Given this list of marker genes Nrp1, Abl1, Abl2, Espnl, Arhgef10l, Mtor, Arhgef10, Fscn1, Fam171a1, Nox4, Pak1, Limch1, Wnt11, Srf, Pdlim4, Pawr, Pik3r1, Myoc, Ccdc88a, Kank4, Ptger4, Lima1, Pls3, Tmeff2, Dpysl3, Cfl1, Kctd13, Rflna, Vil1, Luzp1, Kank2 (KN motif and ankyrin repeat domains 2), Aif1l, Aif1 (NCBI Gene Id 56250), Ptk2b, Sh3pxd2b, Arhgef18, Zyx, Actg1, Inpp5k, Stmn1, Nf2, Flna, Espn, Myh9, Baiap2, Myh10, Was, F11r, Phldb2, Fmn2, Pfn1, Met (NCBI Gene Id 194383), Shroom2, Tsc1, Asap3, Sorbs1, Carmil1, Arap1, Itgb1, Dnm2, Synpo, Kank3, Rhpn2, Bloc1s6, Rhoc, Frmd7, Serpinf2, Itgb1bp1, Swap70, Map3k1, Ush1c, Sdc4, Ezr, Shank1, Lpar1, Spag6l, Fermt2, Wnt4, Tmsb15l, Pdxp, Arrb1, Bag4, Shank3, Fam107a, Add1 (adducin 1), Tjp1, Fhdc1, Arhgap6, Tac1, Bbs4, Ppp1r9a, Smad3, Spire1, Tgfb3, S1pr1, Tpm1, Ccn2, Spire2, Evl, Baiap2l2, S100a10, Limk1, Coro2b, Arhgef5, Sorbs3, Clasp2, Tgfbr1, Dbnl, Rapgef3, Src, Tnfaip1, Cd47, Tacr1, Coro1b, Pfn2, Baiap2l1, Fscn2, Arhgap28, Pfn3, Dmtn, Cul3, Kiss1r, Tesk1, Phactr1, Wasf2, Alms1, Epha1, Gas7, Myo1b, Fhod1, Ttc8, Pfn5, Limd2, Actn1, Cald1, Pik3r2, Synpo2, Synpo2l, Myl9, Actn4, Hsp90b1, Zeb2, Marcks, Rhoa, Pak2, Cx3cl1, Tacstd2 (tumor-associated calcium signal transducer 2), Cdc42, Mtss1, Pxn, Arhgef15, Pls1, Dlc1, Fscn3, Pdlim1, Shroom1 (shroom family member 1), Ppm1f, Prkn, Rflnb (NCBI Gene Id 76566), Itgb5, 4930544G11Rik, Tmsb15b2, Mkks, Eln, Rhod, Gpr65, Braf, Diaph3, Apoa1, Cgnl1, Rgcc, Rac1, Plek, Ppm1e, Dbn1, Add2, Rhpn1, Lcp1, Clasp1, Prkcq, Rdx, Id1, Shtn1, Eps8, Rock2, Ppfia1, here is a description of the gene set: A process that results in the assembly, arrangement of constituent parts, or disassembly of an actin filament bundle. Mouse Gene Set: GOBP_ACTIN_FILAMENT_BUNDLE_ORGANIZATION studied in species Mus musculus